The following is a description of a gene set: studied in species Homo sapiens from publication Chen Y, Wang X (PMID 31504780) Human Gene Set: MIR943 Genes predicted to be targets of miRBase v22 microRNA hsa-miR-943 in miRDB v6.0 with MirTarget v4 prediction scores > 80 (high confidence targets)., and this is the list of marker genes: HECTD2, ZXDA, NTS, ZMAT1, PDCD1LG2, STXBP5, FAM9C, CCNC, RNPS1, KRTAP4-3, TMPO, NKAIN3, NR3C2, TDRD3, STXBP5L, COA7, C8orf44-SGK3, JAZF1, GHSR, MBNL1, PDS5A, FLG2, PRDM5, SAMD12, CIP2A, LHX1, EPM2A, SCARB2, GAS2, OAS1, RAB31, TCAIM, TMEM114, HYAL3, TMED5, MACIR, EEF1E1, CILK1, ARID1B, NSD3, CPEB3, GRIK2, MAEL, TMEM165, EPDR1, ZXDB, SGK3, ABCB11, BRAP, NOL10, FUT9, FAAH, UBE2D2, SC5D, BMP3, MYOZ1 (NCBI Gene Id 58529)